Given this list of marker genes FCGR1A, MICOS10, PITHD1, TXNL4A, SET, SRSF10, ITPA, DCUN1D3, HSPD1, ARHGAP18, SECTM1, C9orf78, IL32, HLA-DPA1, C1orf54, VPS29, ARMC10, RIOK1, POLR2B, HSP90AB1, GTF3A, LTV1, FASTKD3, TAF9, CCL7 (NCBI Gene Id 6354), GLUL, SMCO4, CERS6, PAK1IP1, ITGAM, FCN1, RBM8A, MPHOSPH6, PSMG1, PSMA2, ZNF706, SNRPE, MFSD14B, IKZF4, INO80, ATP1B3, HLA-DRA, SAMHD1, ASCC3, REV1, CTSA, BCCIP, PSMC2, GTPBP4, EMG1, CD1B, HLA-DQB1, SSB, UBE2L6, PSMC5, ETV7, BTBD1, SMARCA4, FGL2, CALHM6, CDK4, RGCC, SERBP1, UBQLN2, ERP29, TARS1, EFCAB2, TIPRL, SMPD1, RPL35A, WARS1 (tryptophanyl-tRNA synthetase 1), GDI2, C1QB, GLUD2, ATP5MK, PSMB2, F3, FUCA2, CH25H, RPL5, HIGD2A, TMCO1, PSMB4, DDX39A, ISCA2, RPL24, TMSB10, YTHDF1, TGFBI, RPL8, HLA-DRB6, KARS1, EEF1B2 (eukaryotic translation elongation factor 1 beta 2), RAD23B, MRPS7, ARMC1, NASP, PTMA, RPL7, RPLP2, CKLF, MAZ, MCMBP, PTBP1, RPL12, GSR, PRCP, VAMP5, TOMM22, ABCE1, UTP18, CTSC, PSMB6, RAN, PLAAT4, ZNF480, CNDP2, MIDEAS, PPIA, ALDH1A2, TEX261, CCT8, MRPL43, FKBP1A, EXOC6, HINT1, CTSZ, SLFN11, FAM174C, GIMAP4, ERLIN1, P2RY14, BATF2, CD74, HLA-DPB1, RPL10A, DAZAP1, CDIPT, DDX21, DNTTIP2, CXCL9, ARHGDIB, FCER2, MAT2A, ZNF593, RRP15, SRGAP2C, GGT5, CRISPLD2, NME1 (NCBI Gene Id 7794), RAB5IF, STEAP4, ATP5MG, IDI1 (isopentenyl-diphosphate delta isomerase 1), CD226, RILP, PSME2, CREM, CD1E, LGALS8, FBP1 (fructose-bisphosphatase 1), AGPAT3, ATP5F1E, BATF3, PSMA5, RPS11, COMMD4, BHLHE41, FPR3, RPS2, ACTG1, SYNCRIP, SNU13, RPS27A, CCND2, LACTB, CCT6A, TWSG1, ZNF468, TRAFD1, SLAMF8, GPX4, RPS16, C2CD5, FCGR1BP, YBX1, PRDX3, FKBP4, BEX2, PSMA4, PPA1, NOP16, RPL37, NSA2, SNX3, PER2, HLA-DQA1, CDV3, SKAP2 (src kinase associated phosphoprotein 2), here is a description of the gene set: Conditional macrophage-specific PPARg knockout mice were generated on C57Bl/6 background by breeding PPARg fl/- (one allele is floxed, the other is null) and lysozyme Cre transgenic mice. PPARg and IL-4 signaling was analyzed on bone marrow-derived macrophages. Bone marrow of 3 mice per group was isolated and differentiated to macrophages with M-CSF (20 ng/ml). 20 ng/ml IL-4 was used to induce alternative macrophage activation and 1 uM Rosiglitazone (RSG) was used to activate PPARg. From each mouse 4 samples were generated: 1. M-CSF, 2. M-CSF+RSG, 3. IL-4 and 4. IL-4+RSG. All compounds were added throughout the whole differentiation process, and fresh media was added every other day. Control cells were treated with vehicle (DMSO:ethanol). After 10 days, RNA was isolated and gene expression profiles were analyzed using Mouse Genome 430 2.0 microarrays from Affymetrix. Human Gene Set: GSE25123_WT_VS_PPARG_KO_MACROPHAGE_DN from publication Szanto A, Balint BL, Nagy ZS, Barta E, Dezso B, Pap A, Szeles L, Poliska S, Oros M, Evans RM, Barak Y, Schwabe J, Nagy L (PMID 21093321) Genes down-regulated in bone marrow-derived macrophages: wildtype versus PPARG knockout. species: Homo sapiens